Given this list of marker genes UGP2, NT5C, DCTPP1, MTPAP, DUT, HSP90AA1, here is a description of the gene set: Human Gene Set: GOMF_PYRIMIDINE_NUCLEOTIDE_BINDING studied in species Homo sapiens Binding to a pyrimidine nucleotide, a pyrimidine nucleoside esterified with (ortho)phosphate.